The following is a description of a gene set: Most stromal cells from selectable follicle C clustered in CL1 (Fig. 3a). Although stromal clusters (CL0, CL1) showed high expression of GNL3 and ARID5B (Fig. 8d), CL0 expressed high levels of XBP1 and SELK (Fig. 8e), both involved in endoplasmic reticulum (ER)-stress-induced apoptosis, whereas CL1 expressed high levels of GPRC5A and TNFRS12A (Fig. 8f). species: Homo sapiens from publication Fan X, Bialecka M, Moustakas I, Lam E, Torrens-Juaneda V, Borggreven NV, Trouw L, Louwe LA, Pilgram GSK, Mei H, van der Westerlaken L, Chuva de Sousa Lopes SM (PMID 31320652) Human Gene Set: FAN_OVARY_CL1_GPRC5A_TNFRS12A_HIGH_SELECTABLE_FOLLICLE_STROMAL_CELL, and this is the list of marker genes: UBE2D3, FGD4, CCNI, SELENOM, TMEM87A, YBX3, LTBP4, CHMP2B, TCEAL1, AK6, SARS1, RAB7A, GLRX, CHMP4B, LUM, NACA, NOP56, PLSCR1, PPIL4, MYADM, CAMLG, UBB, HSP90AA1, STIP1, GADD45A, RPSA, CCT5, VAPA, NAA50, CCT4, SNHG15, RPL5, HNRNPH3, TUBB6, DUSP14, YWHAG, ILF2, TSPYL1, MRFAP1, UGDH, UBE2N (ubiquitin conjugating enzyme E2 N), TCF21, AKAP12, DNAJA1, IFI16, SAP18, AXL, SNRPB, RAN, SERPINF1, PPP2CA, PPP1R15A, STRAP, LHFPL6, RPL14 (ribosomal protein L14), TOMM40, DKC1, HNRNPU, IGFBP5, YBX1, EWSR1, AMD1, SNHG32, CNBP, BAG3, MMP2, EIF1B, NCL, PEA15, RPL24, UBL3, C11orf96, RHEB, TXNL1, EIF3H, EFEMP1, PALLD, ELOC, KDM6B, RPL9, CLTB, MAP1LC3B, PPP2CB, CRY1, XRCC6, STAR, PNRC1, TENT5A, EIF5B, NUDT4, IMPDH2, TMEM70, SLC38A2, UBE2A, UBA2, UBE2D1, MEG3, CALD1, SERBP1, IARS1, SYNCRIP, DEGS1, CTSF, G3BP1, DNAJB6, SQSTM1, RNF139, COL1A2, OGN, DDX21, CFD, GSPT1, MAFF, GSN (gelsolin), EIF4H, ACTG1, TARDBP, MFAP4, TIMP1, UAP1, MAP1B (NCBI Gene Id 4131), DHX15, PRDX1, C1S, RPLP0 (ribosomal protein lateral stalk subunit P0), ATP1B1, LRRC59, H2AX, MAP4K5, LUZP1, GPATCH4, TOP1 (NCBI Gene Id 7150), MAPRE1 (microtubule associated protein RP/EB family member 1), AHSA1, QSOX1, FUBP1, TMEM165, RACK1 (receptor for activated C kinase 1), HSPE1, CCDC47, CACYBP, TMED5, TUBA1C, WDR74, TXNRD1, BAG2, SNU13, EIF3E, PDLIM3, UBAP1, WTAP, COL18A1, DSE, RHOBTB3, CCT2, HNRNPF, EIF3J, ANKRD28, EMP2, CYCS, LAMA4, EEF2, GPRC5A, TBC1D15, PRPF38B, ZNF207, ATG101, EPS8, RPL8, NXT1, ATP6V0D1, CFH, PLTP, BZW1, ARID5B, PPP2R2A, RBBP6, EIF4E, FILIP1L, FGFR1 (fibroblast growth factor receptor 1), NAA15, GNL3, NOP16, GSTM3, GLIS3, NXF1, UTP11, NPM1, COQ10B, SLC1A5, HSPH1, TNFRSF1A, PA2G4, SDC2, MARCHF3, ATF4, KPNA2, RPL13A, COL6A2, JMJD1C, SMARCA5, SFPQ, HNRNPA2B1, MAP2K3, EIF3I, EIF5, TUBA1A, HSPA9, SAFB, KRT19, TMEM176B, H2AZ1, EIF4G2 (NCBI Gene Id 1982), PHLDA1, PNRC2, RTN4, SAFB2, ANXA5, PSMC4, FBL, DIMT1, BRIX1, CYTOR, TNFRSF12A, CAVIN1, DNAJC2, CTNNAL1, PNO1, LGALS3, RPL7L1, OAT (ornithine aminotransferase), C1QBP, SLC3A2, GPC3, RNF10 (ring finger protein 10), MYC, TFAM, COPS3, RPL7A, MGAT1, HSPD1, FHL2, FUNDC2, DCN, HNRNPA3, CEBPZ, CD55, STAT3, PAWR, TRIR, RPL18, APP, HNRNPA1, WDR1, SGK1, SERTAD1, RRS1, HNRNPK, OSER1, RPL10, RPL10A, DCAF13, SPSB1, GEM (GTP binding protein overexpressed in skeletal muscle), PSMD12 (proteasome 26S subunit, non-ATPase 12), UBC, NOLC1, COL1A1, EIF4A3, VIM, MRTO4, TUBB4B, RARRES2, RNPS1, NASP, NGDN, CTSL, MAT2A, NOP53, RB1CC1, SRRM2 (serine/arginine repetitive matrix 2), HNRNPAB, WDR43, CSNK1A1, MRPL32, GNL1, CHD1, CAV1, TCP1, PSMG1, RNF149, NAA20, EIF1AX, CCT3 (chaperonin containing TCP1 subunit 3), YTHDF2, NFIA, KIF5B, C1R, EEF1A1, NME1, RBM25, RPS9, RPL4, GRPEL1, GOLGA4, SPTSSA, LDHA, PNPLA8, XBP1, FKBP4, ERRFI1, CAV2 (caveolin 2), IQCG, TRMT10C (tRNA methyltransferase 10C, mitochondrial RNase P subunit), COLEC11, MORF4L2, RSL1D1, GTPBP4, PABPC1, ATP1A1, ARF4, PPP4R2, LITAF, CNN3, SRP19, HSP90AB1, GCLM, PLOD2 (procollagen-lysine,2-oxoglutarate 5-dioxygenase 2), CCDC80, MLF1, AKIRIN1, NAP1L1, SERPING1, ENO1, SF1, DNAJA2, SGCE, MTDH, ATF1, PRNP, DIRAS3, C7, KLF4, RBM7, CCT6A, NIFK, GLA, MTHFD2, HNRNPH1, AEBP1, HNRNPA0, SPART, TPT1, LMNA, BST2, DDX5, CD63, ETF1, COL6A1, HNRNPC, NBL1, CPE, STK17A, PEG10, EIF4A1, EIF3A, HNRNPDL, DHX9, RPS5, MARCHF5, ST13, TSPAN5, HNRNPM, HSPA8, LRRFIP2, FGF7, EMP1, SSB, SBDS, BTG3